The following is a description of a gene set: Human Gene Set: GOBP_CAVEOLIN_MEDIATED_ENDOCYTOSIS An endocytosis process that begins when material is taken up into plasma membrane caveolae, which then pinch off to form endocytic caveolar carriers. studied in species Homo sapiens, and this is the list of marker genes: PROM2, MAPK1, NEDD4L, MAPK3, MLC1 (NCBI Gene Id 654039), PACSIN2, CAV3, UNC119, CAV1, CLN3, SRC, ITSN1 (intersectin 1)